Given this list of marker genes PLXNB1, RHOB (ras homolog family member B), ARHGAP35, MYL6, MYL9, MYH14, MYH10, LIMK2, ARHGEF12, RAC1, MYH9, RRAS, RND1, MYH11, RHOA, ROCK1, ERBB2, SEMA4D, RHOC, ROCK2, MET, MYL12B, LIMK1, ARHGEF11, here is a description of the gene set: studied in species Homo sapiens Semaphorin 4D (Sema 4D/CD100) is an axon guidance molecule with two disulfide-linked 150-kDa subunits. SEMA4D is structurally defined by a conserved 500-amino acid extracellular domain with 16 cysteines (sema domain) and also an Ig-like domain C-terminal to the sema domain. Sema4D is expressed on the cell surface as a homodimer; cysteine 679 within the sema domain is required for this dimerization.<br>The main receptors for Sema4D are plexin-B1 and CD72. The activation of plexins by semaphorins initiates a variety of signaling processes that involve several small GTPases of the Ras and Rho families. Sema4D-Plexin-B1 interaction appears to mediate different and sometimes opposite effects depending on the cellular context. Plexin-B1 activation inhibits integrin-mediated cell attachment and cell migration through the activation of the R-RasGAP activity inherent to plexin-B1 or through the inhibition of RhoA. However, activation of plexin-B1 by Sema4D stimulates the migration of endothelial cells by mediating the activation of RhoA. Reactome Pathway: Sema4D in semaphorin signaling part of: Semaphorin interactions